Given this list of marker genes LMNB1, KIF20B, PBK, ADARB1, RACGAP1, MAF, NUSAP1 (NCBI Gene Id 82534), ZFY, BARD1, MRE11, CENPA, BIRC5, NUP62, EZH2, TPX2, CENPE, TOP2A, CDK1, TREM1, TK1, NEK2, KIF20A, CCNA2, OR1E1, CDC25A, SMC4, CCNB2, SPAG5, KIF23, PLK4, KIF4A, BUB1, PDP1, TCF4, FOSL2, PTTG3P, H2AC16, ADH1B, MAP1B, PRC1, EXOSC9, TTK, UBE2C, AURKB, CDC20, IGFBP5, CTH, TFAM, FBXO5, PTTG1, KIF11, DBF4 (NCBI Gene Id 10926), IL12RB2, NRGN, PPL, QPCT, here is a description of the gene set: species: Homo sapiens Genes down-regulated in WI-38 cells (senescent primary fibroblasts) after inactivation of TP53 by GSE56 polypeptide. Human Gene Set: TANG_SENESCENCE_TP53_TARGETS_DN The tumor suppressor p53 is a key modulator of the cellular stress response, inducing cell-cycle arrest, apoptosis, senescence and cell differentiation. To evaluate further the molecular mechanism underlying p53 function, the transcriptional profiles of proliferating and senescent WI-38 cells, both wild-type p53 expressers and counterparts with an inactivated p53, were compared by DNA microarray analysis. In particular, the amyloid-beta precursor-like protein 1 (APLP1) is induced in senescent cells in a p53-dependent manner. APLP1 was confirmed to be a novel transcriptional target of p53 by in vivo and in vitro characterization of a p53 responsive element found in the first intron of the APLP1 gene locus. APLP1 knockdown experiments demonstrate that APLP1 is required for the proliferation of fibroblastic and epithelial cells. Moreover, depletion of APLP1 expression diminishes stress-induced apoptosis of neural cells, whereas ectopic APLP1 expression augments apoptosis. Based on these data, a mechanism is proposed whereby p53-dependent induction of APLP1 is involved in neural cell death, and which may exacerbate neuronal cell loss in some acute or chronic neurodegenerative disorders. from publication Tang X, Milyavsky M, Goldfinger N, Rotter V (PMID 17533371)